The following is a description of a gene set: Human Gene Set: GSE21546_ELK1_KO_VS_SAP1A_KO_AND_ELK1_KO_ANTI_CD3_STIM_DP_THYMOCYTES_DN Removal of the transcription factor SAP1a member of the Ternary Complex Factor (TCF) group of transcription factors which in conjunction with Serum Response Factor (SRF) has been shown to have a profound effect on positive selection in the thymus. When another TCF Elk1 is knocked out in mice there is no effect on positive selection unless it is on a Sap1a KO background where the phenotype is very severe. We have stimulated isolated double positive T cells (DPs) with anti-CD3 to mimic positive selection and compared basal and stimulated transcription across the four genotypes to discover the downstream targets of Sap1a involved in positive selection. Genes down-regulated in stimulated by anti-CD3 double positive thymocytes: ELK1 knockout versus ELK1 and ELK4 knockout. studied in species Homo sapiens from publication Costello P, Nicolas R, Willoughby J, Wasylyk B, Nordheim A, Treisman R (PMID 20554967), and this is the list of marker genes: TCIM, ACOT13, GUSB, ASIC3, TMEM200A, CENPU, B3GNT3, ABL2, PIM1, CCDC71L, KCNJ6, UTP25, RGS16, SPRY4, LMF2, MAPKAPK2, DHX29, GABPB1, EIF2B2 (eukaryotic translation initiation factor 2B subunit beta), SLC1A1, SPRY2, KCNJ14 (NCBI Gene Id 3770), SERPINB12, TAGLN2, DUSP16, ITIH3, PLA2G5, PGF, FIBCD1, SKIL (NCBI Gene Id 6498), SARAF, HSD17B12, GRSF1, EGR1, SELENON, ILRUN (inflammation and lipid regulator with UBA-like and NBR1-like domains), POLR1B, DPCD, INPPL1, ZNF469, CCDC107, KCMF1, SEPTIN1, RTCA, KANSL1, OSGIN1, BDP1, UBAP1, ANKRD11, HSF2, MRPL20, PLCB2, EFHD2, NFKBID, CABS1, NGEF, TBC1D1, SAMTOR, KCTD4, PLK2, ARL8B, TNFAIP3, TAF1A, SCGN, LZTS2, ARHGAP21, DENND1C, IZUMO1, UBE2F, ZNF623, PKN2 (protein kinase N2), DNAJB6, UPP1, MAPKAPK5, PLEKHF1, NR4A1, BMP5, WDR83OS, PHLPP2, ZNF777, ZNF703, CPEB1-AS1, LY6D, CSRNP1, CHKA (NCBI Gene Id 1119), DYRK3, CNGA1, CDV3, INPP5F, PDXP, PER1, CLK3, SLC30A1, SUCO, DENND1B, SQSTM1, EXOC5, MARVELD2, TRHR, TFB2M, CDK17, DHFR, GEM, ELFN1 (NCBI Gene Id 652055), TREML4, MTA1, FBXO34, ZNF655, HSPE1, KCNT1, DUSP2, CBS, ZNF367, QPCT, HSPH1, EDN2, DYRK2, PAK6, CRHR2, FBXO30, DDX6, SRP72, AREG, CSNK1G1, JARID2, BAG3, ETS1, CDC25A, ACSM1, IL10RA, GLE1, AZI2, SLCO1C1, ZFAND2A, AHSA1, HSPA8, PPP1R13L, IL3RA, LPIN2, OPN3, NUDT6, HAPSTR1, YTHDF1 (NCBI Gene Id 54915), PTBP1, JADE1, KIAA0232, YTHDC1, CREB5, NPM3, ARHGEF26, STIP1, CCNT1, BNC1, ARL5B, SPATA25, BABAM2, LY6H, BEND3, LRATD1, RBM12 (RNA binding motif protein 12), GADD45B, MED13, UBE2B (ubiquitin conjugating enzyme E2 B), KLHL28, NMT2, IPMK, PITHD1, MDM2, CXCL3, RCVRN, TRAF6, DUSP8, USPL1, MANBAL, B4GALT5, SNPH, DHX16, ARL4D, CHORDC1, CLEC2L, CDC42SE1, SKP1, NIPSNAP3B (NCBI Gene Id 55335), SERP1, OGA, CCDC117, RUFY3, TMCC1, CORO1C, CDK3, DUSP6, TNFRSF1B, BCL6, TRAPPC9, KRT72, MFHAS1, PHRF1, SH3BP2, CNPY3, CABLES2